The following is a description of a gene set: from publication Chen Y, Wang X (PMID 31504780) Genes predicted to be targets of miRBase v22 microRNA mmu_miR_7677_3p in miRDB v6.0 with MirTarget v4 prediction scores > 80 (high confidence targets). Mouse Gene Set: MIR_7677_3P studied in species Mus musculus, and this is the list of marker genes: Aptx, Rem2, Slc35d3, Kif2a, Foxa1